The following is a description of a gene set: species: Mus musculus Activation of RAC1 downstream of NMDARs Mouse Gene Set: REACTOME_ACTIVATION_OF_RAC1_DOWNSTREAM_OF_NMDARS, and this is the list of marker genes: Camk1, Calm1, Calm2, Calm3, Camkk1, Camkk2